The following is a description of a gene set: part of: Signaling by ALK in cancer Aberrant ALK activity arises through fusions, point mutations, overexpression or amplifications and has been shown to be an oncogenic driver in a number of cancers including anaplastic large cell lymphoma (ALCL), non-small cell lung cancer (NSCLC), inflammatory myofibroblastic tumors (IMTs) neuroblastomas and more. As a result, ALK is a promising therapeutic target for inhibition with tyrosine kinase inhibitors. Crizotinib, ceritinib, brigatinib, alectinib and lorlatinib are all approved for the treatment of ALK-driven cancers, however resistance commonly develops either as a result of accumulating secondary mutations, or through activation of bypass pathways that remove the dependence on ALK signaling. Reactome Pathway: Drug resistance of ALK mutants studied in species Homo sapiens, and this is the list of marker genes: ALK